The following is a description of a gene set: Mouse Gene Set: GOBP_ADULT_FEEDING_BEHAVIOR Feeding behavior in a fully developed and mature organism. species: Mus musculus, and this is the list of marker genes: Agrp, Usp46, Ghrl, a, Cartpt (NCBI Gene Id 27220), Ghsr, Gpr39, Lep, Dmbx1, Npy